The following is a description of a gene set: studied in species Homo sapiens Any process that stops, prevents, or reduces the frequency, rate, or extent of a T cell mediated immune response to tumor cell. Human Gene Set: GOBP_NEGATIVE_REGULATION_OF_T_CELL_MEDIATED_IMMUNE_RESPONSE_TO_TUMOR_CELL, and this is the list of marker genes: PDCD1, MAPK3, CD274, AHR, UFL1, IL4I1 (interleukin 4 induced 1), USP5